Given this list of marker genes PYCARD, TMOD1, CALD1, TNNT2 (troponin T2, cardiac type), LMOD1, TMOD4, S100A6, TMOD2, SMTNL1, LMOD2, TNNT3, TNNT1, NEBL, LMOD3, TMOD3, here is a description of the gene set: Binding to tropomyosin, a protein associated with actin filaments both in cytoplasm and, in association with troponin, in the thin filament of striated muscle. species: Homo sapiens Human Gene Set: GOMF_TROPOMYOSIN_BINDING